The following is a description of a gene set: Mouse Gene Set: MIR_3078_5P Genes predicted to be targets of miRBase v22 microRNA mmu_miR_3078_5p in miRDB v6.0 with MirTarget v4 prediction scores > 80 (high confidence targets). from publication Chen Y, Wang X (PMID 31504780) species: Mus musculus, and this is the list of marker genes: Kdm7a, Dmxl2, Pafah1b2, Nol9, Gprc5b, Arrdc3, Phykpl, Pde1c, Rftn1 (raftlin lipid raft linker 1), Slitrk2, Tmpo, Thbs2, Edc3, Pak5, Pramel34, Vangl1 (NCBI Gene Id 229658), Actl6a, Bbip1, Dpysl2, Chmp4b, Nkain2, Ddx3x, Ndst4, Klf6, Ptbp2, Vil1, Garre1, Dtl, Sh3kbp1, Pld1, Rad21, Tle1, Tmem150b, Hbs1l, Hs2st1, Srsf6, Slc30a1, Bcl9, Foxo4, Tnfrsf11b, Etnk1, Trmt10a (tRNA methyltransferase 10A), Slc5a3, Rbm26, Zc3h11a, Cxcl9 (C-X-C motif chemokine ligand 9), Opn5, Fsd1l, Slc27a4, Fbxo33, Sel1l, Eomes, Sp3, Coro1a, Tnip3, Slc12a5, Otud4, Srsf7, Pdp1, Cdh9, Sgms1, Synj2bp, Phf6, Rnf19a, Tasor2, Calb1, Prkar2b, Gcn1, Rel, 1700030K09Rik, Pdcd6ip, Dcp2, Lrrc59, Zfhx2, Nr4a3, Btbd10, Ssx2ip, Wee1, Tmem26, Zfp300, Cbfa2t3 (NCBI Gene Id 320906), Gigyf2, Cdh2, Osbpl1a, Arfip1, Baiap2, Musk, Lrrc75b (leucine rich repeat containing 75B), C1ql3, Lmbrd2, Nucks1, Tctn2, Neurog2, Oprk1, Palld, Cbll1, Mbtps2, Gls, Tox3, Cyb561